The following is a description of a gene set: The process whose specific outcome is the progression of the cardiac myofibril over time, from its formation to the mature structure. A cardiac myofibril is a myofibril specific to cardiac muscle cells. Human Gene Set: GOBP_CARDIAC_MYOFIBRIL_ASSEMBLY species: Homo sapiens, and this is the list of marker genes: TTN (titin), SRF, MYL2, NKX2-5, FHOD3, PDGFRA, SMAD4, MYH10 (myosin heavy chain 10), MEF2A, MYLK3, ACTC1, PROX1, NEB, NRAP, NEBL, ADPRHL1, CSRP3, OBSL1, PDGFRB, TCAP